Given this list of marker genes IL25, GATA1, TRIB1, GATA2, STAT5A, IL5, LYN (NCBI Gene Id 4067), here is a description of the gene set: species: Homo sapiens The process in which a relatively unspecialized myeloid precursor cell acquires the specializes features of an eosinophil. Human Gene Set: GOBP_EOSINOPHIL_DIFFERENTIATION